Given this list of marker genes Ctse, Srgn, Ctsb, Fpr1, Elane, Man2c1, Lyz2, Ctsg, Lcn2, Cpa3, Mpo, Mcpt8, Camp, Ctss, Ctsh, Ngp, Ctsc, Ctsd, Ctsl, Gusb, Cybb, Ltf, Prg3, Mmp9, Itgb2, Mmp13, Scarb2, here is a description of the gene set: Mouse Gene Set: LIAN_NEUTROPHIL_GRANULE_CONSTITUENTS Although the mature neutrophil is one of the better characterized mammalian cell types, the mechanisms of myeloid differentiation are incompletely understood at the molecular level. A mouse promyelocytic cell line (MPRO), derived from murine bone marrow cells and arrested developmentally by a dominant-negative retinoic acid receptor, morphologically differentiates to mature neutrophils in the presence of 10 microM retinoic acid. An extensive catalog was prepared of the gene expression changes that occur during morphologic maturation. To do this, 3'-end differential display, oligonucleotide chip array hybridization, and 2-dimensional protein electrophoresis were used. A large number of genes whose mRNA levels are modulated during differentiation of MPRO cells were identified. The results suggest the involvement of several transcription regulatory factors not previously implicated in this process, but they also emphasize the importance of events other than the production of new transcription factors. Furthermore, gene expression patterns were compared at the level of mRNA and protein, and the correlation between 2 parameters was studied. (Blood. 2001;98:513-524) from publication Lian Z, Wang L, Yamaga S, Bonds W, Beazer-Barclay Y, Kluger Y, Gerstein M, Newburger PE, Berliner N, Weissman SM (PMID 11468144) studied in species Mus musculus Granule constituents expressed during mouse promyelocytic cell line differentiation to neutrophils.